The following is a description of a gene set: studied in species Homo sapiens Human Gene Set: HE_LIM_SUN_FETAL_LUNG_C2_NEUTROPHIL_CELL Neutrophil from publication He P, Lim K, Sun D, Pett JP, Jeng Q, Polanski K, Dong Z, Bolt L, Richardson L, Mamanova L, Dabrowska M, Wilbrey-Clark A, Madissoon E, Tuong ZK, Dann E, Suo C, Goh I, Yoshida M, Nikolić MZ, Janes SM, He X, Barker RA, Teichmann SA, Marioni JC, Meyer KB, Rawlins EL (PMID 36493756), and this is the list of marker genes: S100P, AQP9, PELATON, LINC03078, ADGRE3, VNN1, VNN3P, CKAP4, FPR2, S100A8, CYFIP2, ORM2, SLC11A1, LRRK2, CYP1B1, ECE1, HP, RAB27A, TNFAIP6, ORM1, HK3, LINC00937, NFE2, MGAM, LTB4R, ACSL1 (acyl-CoA synthetase long chain family member 1), TREM1, PGLYRP1, ADM, CPD, FCAR, RBP7, TNFRSF10C, AP5B1, ADGRG3, PADI2, MCEMP1, PADI4, VNN2, DYSF, IGF2R, STEAP4, FCGR3B, FOLR3, LILRA5 (NCBI Gene Id 95091), CLEC4E, ANXA3, CLEC5A, RGL4, PROK2, MEGF9, CMTM2 (CKLF like MARVEL transmembrane domain containing 2), THBS1, S100A12, G0S2, F5, ASGR1, QPCT, HK2, MTARC1 (NCBI Gene Id 64757), TUBA4A, CDA, CLEC4D, APOBEC3A, DGAT2 (diacylglycerol O-acyltransferase 2), BST1